The following is a description of a gene set: Human Gene Set: HP_LONG_TOE Long toe Toes that appear disproportionately long compared to the foot. species: Homo sapiens, and this is the list of marker genes: COL12A1, KMT2A, NPR2, SMARCA2, SMS, PAPPA2, GNE, TBX4, B4GALT7, PUF60, FLI1, POLR3GL, IPO8, KCNN3, DLK1 (delta like non-canonical Notch ligand 1), NPR3, NKX3-2, XYLT2, PRKAR1A (protein kinase cAMP-dependent type I regulatory subunit alpha), TRAF7, ZEB2, COL6A2, SOX5, GNAI1, POLR3A, IRX5, KMT5B, KCNH1, CPT2, MEG3, GATAD2B, COL6A3, FAM20C, TMEM94 (transmembrane protein 94), FBN1, PTH1R, LARS1, ZNF668, NSDHL, KAT6B, PHF8, RTL1, COL6A1, SCARF2, FIBP, DPM1